The following is a description of a gene set: Mouse Gene Set: GOBP_SPERMATID_NUCLEUS_ELONGATION The change in shape of the spermatid nucleus from a spherical structure to an elongated organelle, during the latter part of spermatid differentiation. studied in species Mus musculus, and this is the list of marker genes: Dmrtc2, Kdm3a, Cfap61, Ift88, Tnp1, H1f7